Given this list of marker genes ADPGK, SPINK8, SQOR, POMT2, ASB2 (ankyrin repeat and SOCS box containing 2), SYT3, LPIN1, MRPL11, LYRM7, DNAJC19, SPATA2, GATM, COQ7, PEBP4, MMP24, LYAR, UBE2V2, ADK (NCBI Gene Id 132, adenosine kinase), GOLM1, COX6B1, SLC23A1, LEFTY1, LAMC1, TAT, GPR174, CDCA3, TNXB (NCBI Gene Id 7148), UFM1, PFKM, FASTKD2 (FAST kinase domains 2), EHD1, MRPL42, MTARC2, HASPIN, GPR45, CCNA2, BDH1, CYP27B1, ZNF142, NDUFA1, NSG2, B3GNT8 (NCBI Gene Id 374907), MLC1, PNO1, FASTKD5, GSR, AGTR1, GALNS, CANX, CHCHD4, KPNA3, RMDN3, HAT1, KCNN4, FLRT1, SETD6 (SET domain containing 6, protein lysine methyltransferase), MACIR, TTLL12, NECAP2, REXO2, ELP5, PPM1G, QNG1, GFI1B, NIPA1, AKIRIN1, MRPS18A, MYO1D, TIFA, MYL1, RAD23A, PTDSS2, DTNA, PPAT, TTLL11, SH2B2, MINDY3, KCTD4, EXOC5, TESC, CD247, BRCA1, TMC5, RBFOX2, SNTA1, SDHB, SCN2B, ORC5, CCDC7, SLC1A7, NUP50, PDAP1, CENPV, GLYCTK, GABRA6, PHB1, SPATS2L, STN1, TM7SF3, SLC5A1, NHSL2, TUBB2A, PON2, PRUNE2, ACSM2A, ARL13A, NRP1, SLC25A22, MRPL20, PRSS41, BCCIP, ITK, SLC4A11, ASPM, TBCCD1, EIF2B1, MID1IP1, CHD5, EIF3A, USP24, NDUFS7, CLTC, MRS2, IL6ST, TMEM97, OSTM1, AFG3L2, SNTG2, UQCR11, MAN2A1 (NCBI Gene Id 4124), MFHAS1, STARD10, EPOR, UROD, GPSM2, PTRH1, SAP30, TENT5A, NCBP1 (NCBI Gene Id 4686), CCL28 (C-C motif chemokine ligand 28), GEN1, KIF1C, CASK, HELQ, TRMT6, SOX5, KLHL12, KCNK1, PSMD14 (proteasome 26S subunit, non-ATPase 14), SKOR1, ADAM28, PTCD3, PGRMC2, UTP6, CARNMT1, DHH, NARF, PSMD12, IL7R, VWA3A, HACD1, GUK1, NMNAT3, ITGA1, CRTAM, ATPAF2, ELAVL1 (NCBI Gene Id 1994), CITED4, IDH3A, LIAS, NARS1, HBG2, SAMM50 (NCBI Gene Id 25813), SERINC5, CNGA1, MRPS18C, FBXO10, CBLIF, SLPI, HSPA2, COX17, LMAN1, ID2, LMNA, RFC5, SLC20A1, MRPL50, STOM, MTA2, NPHP3, TEX44, ZNF750, ISCA2, BLOC1S5, MBD2, MB21D2, DDX28, CLRN3, C11orf24, MEMO1, here is a description of the gene set: Genes down-regulated in comparison of LSK versus lineage negative cells. studied in species Homo sapiens from publication Konuma T, Nakamura S, Miyagi S, Negishi M, Chiba T, Oguro H, Yuan J, Mochizuki-Kashio M, Ichikawa H, Miyoshi H, Vidal M, Iwama A (PMID 21540074) Each fraction of mouse hematopoietic cells was purified by cell sorting from bone marrow of 8-week-old C57BL/6 mice, and its gene expression was analyzed. Human Gene Set: GSE27786_LSK_VS_LIN_NEG_CELL_DN